Given this list of marker genes HTT, MDK, UCN, SHANK3, NRXN1, NRXN2, ATP1A2, XPC, FOXP2, DCANP1, ATOH7, GAP43, CNTNAP2, TACR1, CXCL10, CALB1, SLITRK6 (SLIT and NTRK like family member 6), PTN (pleiotrophin), CHRNA9, SCN11A, ATP8A2, NEUROG1, ERCC8, SLC1A3, DRD2, APP, STRA6, KCNQ3, CHRNA10, SLC26A5, ABHD12, KCNC1, KIAA0319L, KIAA0319, USP53, TIFAB, here is a description of the gene set: species: Homo sapiens Any process that results in a change in state or activity of a cell or an organism (in terms of movement, secretion, enzyme production, gene expression, etc.) as a result of an auditory stimulus. Human Gene Set: GOBP_RESPONSE_TO_AUDITORY_STIMULUS